Given this list of marker genes CFAP95, MNS1, DUSP21, CIMIP2C (ciliary microtubule inner protein 2C), EFHC2, SPAG8, TEKT2, TEKT3, EFHC1, NME7, CFAP53, CFAP161, CFAP141, SAXO4, RIBC1, RIBC2, EFCAB6, TEKTIP1, CIMIP2A, TEKT5, SPMIP8, EFHB, PIERCE2, PIERCE1, TEKT1, SPMIP11, SPMIP9, CFAP107, TEKT4, CFAP68, SPMIP6, here is a description of the gene set: A structural network of microtubule inner proteins (MIPs) located inside the lumen of the A tubule of the axonemal microtubule doublet that helps stabilize the A tubule. Human Gene Set: GOCC_AXONEMAL_A_TUBULE_INNER_SHEATH species: Homo sapiens